The following is a description of a gene set: studied in species Homo sapiens Human Gene Set: GOMF_JUN_KINASE_BINDING Binding to JUN kinase, an enzyme that catalyzes the phosphorylation and activation of members of the JUN family., and this is the list of marker genes: SPAG9, DUSP10, MAPK8IP3 (mitogen-activated protein kinase 8 interacting protein 3), HES1, PTK2, GSTP1, MAD2L2, MAPK8IP1, RNF13, DUSP16, MAPK8IP2